The following is a description of a gene set: studied in species Homo sapiens Human Gene Set: DAZARD_UV_RESPONSE_CLUSTER_G2 from publication Dazard JE, Gal H, Amariglio N, Rechavi G, Domany E, Givol D (PMID 12771951) To gain insight into the transformation of epidermal cells into squamous carcinoma cells (SCC), we compared the response to ultraviolet B radiation (UVB) of normal human epidermal keratinocytes (NHEK) versus their transformed counterpart, SCC, using biological and molecular profiling. DNA microarray analyses (Affymetrix), approximately genes) indicated that the major group of upregulated genes in keratinocytes fall into three categories: (i). antiapoptotic and cell survival factors, including chemokines of the CXC/CC subfamilies (e.g. IL-8, GRO-1, -2, -3, SCYA20), growth factors (e.g. HB-EGF, CTGF, INSL-4), and proinflammatory mediators (e.g. COX-2, S100A9), (ii). DNA repair-related genes (e.g. GADD45, ERCC, BTG-1, Histones), and (iii). ECM proteases (MMP-1, -10). The major downregulated genes are DeltaNp63 and PUMILIO, two potential markers for the maintenance of keratinocyte stem cells. NHEK were found to be more resistant than SCC to UVB-induced apoptosis and this resistance was mainly because of the protection from cell death by secreted survival factors, since it can be transferred from NHEK to SCC cultures by the conditioned medium. Whereas the response of keratinocytes to UVB involved regulation of key checkpoint genes (p53, MDM2, p21(Cip1), DeltaNp63), as well as antiapoptotic and DNA repair-related genes - no or little regulation of these genes was observed in SCC. The effect of UVB on NHEK and SCC resulted in upregulation of 251 and genes, respectively, and downregulation of genes in NHEK and genes in SCC. To further analyse these changes, we used a novel unsupervised coupled two-way clustering method that allowed the identification of groups of genes that clearly partitioned keratinocytes from SCC, including a group of genes whose constitutive expression levels were similar before UVB. This allowed the identification of discriminating genes not otherwise revealed by simple static comparison in the absence of UVB irradiation. The implication of the changes in gene profile in keratinocytes for epithelial cancer is discussed. Cluster G2: genes increasingly up-regulated in NHEK cells (normal keratinocyte) and reaching maximum levels at 12 h and 24 h after UV-B irradiation., and this is the list of marker genes: TOB1, PSMD8, GADD45A, ATF4, CXCL8, H2AC20, GFUS, LY6E, IER3, H2AC13, UBE2S, PMAIP1, ATF3, PHLDA2, JUND, CLDN4, CSRP1, JUNB, TACSTD2, CCL20, HLA-F, SGK1, H2AC8, BAMBI, CXCL2, CITED2, NEFM, CXCL3, CCN2 (NCBI Gene Id 1490), INSL4